The following is a description of a gene set: Human Gene Set: HP_ELEVATED_BRONCHOALVEOLAR_LAVAGE_FLUID_NEUTROPHIL_PROPORTION Elevated bronchoalveolar lavage fluid neutrophil proportion Usually, Neutrophils make up less than 3% of all cells found in the broncho-alveloar lavage fluid. In children, standard value of neutrophils is higher depending on their age (children under the age of 5 show a maximum value of 10%). This elevated cell proportion is a sign for acute and chronic infections (HP:0012387, HP:0006538) and can be associated to specific diseases. species: Homo sapiens, and this is the list of marker genes: TERT, MUC5B, NKX2-1, SFTPA2, SFTPA1, SFTPC